The following is a description of a gene set: Antifungal immunity through the induction of T-helper 17 cells (TH17) responses requires the production of mature, active interleukin-1beta (IL1B). CLEC7A (dectin-1) through the SYK route induces activation of NF-kB and transcription of the gene encoding pro-IL1B via the CARD9-BCL10-MALT1 complex as well as the formation and activation of a MALT1-caspase-8-ASC complex that mediated the processing of pro-IL1B. The inactive precursor pro-IL1B has to be processed into mature bioactive form of IL1B and is usually mediated by inflammatory cysteine protease caspase-1. Gringhuis et al. showed that CLEC7A mediated processing of IL1B occurs through two distinct mechanisms: CLEC7A triggering induced a primary noncanonical caspase-8 inflammasome for pro-IL1B processing that was independent of caspase-1 activity, whereas some fungi triggered a second additional mechanism that required activation of the NLRP3/caspase 1 inflammasome. Unlike the canonical caspase-1 inflammasome, CLEC7A mediated noncanonical caspase-8-dependent inflammasome is independent of pathogen internalization. CLEC7A/inflammasome pathway enables the host immune system to mount a protective TH17 response against fungi and bacterial infection. studied in species Homo sapiens Reactome Pathway: CLEC7A/inflammasome pathway part of: CLEC7A (Dectin-1) signaling, and this is the list of marker genes: IL1B, MALT1, NFKB1, PYCARD, RELA, CASP8